The following is a description of a gene set: from publication Kyng KJ, May A, Stevnsner T, Becker KG, Kølvrå S, Bohr VA (PMID 15897889) Human environmental etress response genes not changed in primary fibroblasts from old donors in response to 4NQO treatment. Human Gene Set: KYNG_ENVIRONMENTAL_STRESS_RESPONSE_NOT_BY_4NQO_IN_OLD studied in species Homo sapiens The accumulation of DNA damage and mutations is considered a major cause of cancer and aging. While it is known that DNA damage can affect changes in gene expression, transcriptional regulation after DNA damage is poorly understood. We characterized the expression of genes in human primary fibroblasts after exposure to three different kinds of cellular stress that introduces DNA damage: 4-nitroquinoline-1-oxide (4NQO), gamma-irradiation, or UV-irradiation. Each type of stress elicited damage specific gene expression changes of up to 10-fold. A total of genes had similar changes in expression of 3-40-fold after all three kinds of stress. We examined transcription in cells from young and old individuals and from patients with Werner syndrome (WS), a segmental progeroid condition with a high incidence of cancer, and found various age-associated transcriptional changes depending upon the type of cellular stress. Compared to young individuals, both WS and old individuals had similarly aberrant transcriptional responses to gamma- and UV-irradiation, suggesting a role for Werner protein in stress-induced gene expression. Our results suggest that aberrant DNA damage-induced gene regulation may contribute to the aging process and the premature aging in WS., and this is the list of marker genes: EIF3L, NDRG1, GNPNAT1, TAF1C, TP53I11, CCNL2, HGF, FLOT1 (flotillin 1), SYK, LCK, SOX9, TAF10